Given this list of marker genes PDE4D, UNC45A, RNF125, BMPR1A, SUMF1, MEIS2, FLNA, PTEN, HS6ST2, ARID2, ODC1, GNB2, SRC, TMLHE, AMMECR1, SPOP, TAOK1, VPS33A, POU4F1, TOE1, STXBP1, FMR1, CAMTA1, LMX1B, STRADA, LEMD2, here is a description of the gene set: Human Gene Set: HP_LARGE_FOREHEAD Large forehead species: Homo sapiens